The following is a description of a gene set: A process in which a protein is transported to, or maintained in, a location within the cytoskeleton. Human Gene Set: GOBP_PROTEIN_LOCALIZATION_TO_CYTOSKELETON species: Homo sapiens, and this is the list of marker genes: HNRNPU, GAS2L1, GAS2L2, CEP78, ABL1, MARK4, MAPRE3 (NCBI Gene Id 22924), MCPH1, CEP83, PARD6A, MAPRE1, GOLGB1, CEP250, FAM83D, SPAG5, FILIP1, KLHL21, BICD1, TTBK2, CEP350, DVL1, MID2, NSFL1C, CEP192, CTTNBP2NL, TTK, CSNK1D, LUZP1, HTR2A, FAM83H, STIL (STIL centriolar assembly protein), ABHD17B, MAPRE2 (microtubule associated protein RP/EB family member 2), RAB11FIP3, NUMA1, KIAA0753, STK3, CEP131, MAP1A, MID1, NUP62, PPP1R9B, SNX10, KIF20B, DCTN2, PCM1, FILIP1L, DIAPH1, BBS4, APC, HOOK3, AURKA, CRIPT, RAB11A, DISC1, TRIM69 (tripartite motif containing 69), CCDC14, ABHD17C, NUDCD3, CHAMP1, C2CD3, UBXN2B, PIBF1, GSK3B, CEP72, ABHD17A